Given this list of marker genes FBLN5, MAPRE2, TUBB, ALDH18A1, ELN, GGCX, here is a description of the gene set: Human Gene Set: HP_INCREASED_NUMBER_OF_SKIN_FOLDS species: Homo sapiens Increased number of skin folds